The following is a description of a gene set: studied in species Homo sapiens Human Gene Set: MODULE_354 AA biosynthesis., and this is the list of marker genes: SDS, CA7, ALDH1L1, CA3, CA4, CA2, CBS, PAH, CA5A, PTPRZ1, PTPRG, AHCY, MTHFD1, CA6, OAT, CTH, CA1, CA8